Given this list of marker genes TDRD5, ANK3, JAG1, DIO2, CNTNAP4, ROGDI, CD68, PPOX (protoporphyrinogen oxidase), ASF1A, QRFP, NPM3, SMAD1, HIVEP1 (NCBI Gene Id 3096), ZNF593, GATA6, SLITRK1, TNFRSF12A (TNF receptor superfamily member 12A), PRKCH, CACNA1D, COMMD10, RHOD, ST3GAL5, DMD, ELMOD1, NHLH1, SP6, WDR73, ZMIZ1, ENSG00000291228 (novel transcript), FBXW7, MEPCE, TRAPPC14, LMNA, CYFIP2 (NCBI Gene Id 81032), EN1, MRPL17, JAKMIP2, ARMC6, RUNX1, OLFM4, DUSP9 (NCBI Gene Id 1852), TLE3, SYT12, TMTC2, LIN28A, BCAR3, DOCK7, STOML2, GDPD4, CLEC18C, SALL3, CASQ2, MYO1C, STMN2, TRPM8, CSHL1, SLC37A2, MYL1, BNC2, CRIM1, C12orf42, SMPX, CCDC71L, SARS2, SAMD12, INHBA (NCBI Gene Id 3624), FOXO4, VGLL4, PRKAG1 (NCBI Gene Id 5571), VCPKMT, ELAVL4, BZW2, LMO3, LINC00052, TMEM126B, CCDC122 (coiled-coil domain containing 122), FCHSD1, PRIMA1, PRDM8, GH1, CHRNA10, CREB5 (cAMP responsive element binding protein 5), ZCWPW1, CSH2, ZIC2, ZNF384, SIX1, SESN3, IL3, RLIM, PDZRN4, PRKAA1, TMEM119, SOX14, KCTD8, SPTB, ZNF579, TBR1, HOXA5, MACROH2A2, SEPHS1, IKZF2, RTN3, PIAS1, TRPS1, ADCYAP1, TMEM88, CSH1, ZIC5, TMIE, DPYD, POU2F1, RORB (NCBI Gene Id 6096), STK40, CLRN1, STK32C, LINC01565, UBE4B, MEIS2, GPR88, MKS1, TMEM74B, GBX2, TFAP2D, FGF12, ZNF516-DT, GORAB, SLC26A8, SPRYD3, ZBTB18, FHDC1, PRDX5, ATRNL1, BAIAP2L2, OTP, NIPBL, TMCC2, SKIL, MAPK9, DLST, STAC2, HOXB5, MSANTD2, LUC7L3, BMP4 (NCBI Gene Id 652), DICER1, RTN4, NRP1, OTUD7B, MRPS12, PDE2A, ZIC4, PKP4, EPO, MYBPC1, RIPK4 (receptor interacting serine/threonine kinase 4), ANKMY2, CALCR, UHRF1, VGF, MAP2, MYO15A, CPNE1, DPY19L3, DCX, HESX1, GRK6, WNT11, FOXD3, CYP46A1, PCSK5 (proprotein convertase subtilisin/kexin type 5), TRMT1L, MYH2, SOX4, ZIC1, FZD8, FGF9, RORA, THBS2, EIF4E, SLC25A26, PURA, GAP43 (growth associated protein 43), NAALADL2 (N-acetylated alpha-linked acidic dipeptidase like 2), PTPRD (NCBI Gene Id 5789), SYT16, EBF2, PRL, HDAC9, ZNF423, IL21, PIK3R3, HOXC6, HMCES, MAP3K13, PCF11, ESRRG, GPC3, ADAMTS5, SWT1, CDC42EP3, FLRT3, PRR34, BACE2, EN2, MYO18A, CDIN1, TIAL1, AQP3, CACNG2, DLGAP4 (DLG associated protein 4), ZNFX1, PHOX2B, DIAPH1, KRT20, NPHP4, TPH2, SKP1, TRMT112, TYRO3, IL5, APBB1, OTX2, SUGP2 (SURP and G-patch domain containing 2), HOXD10, PTHLH, PDLIM5, IARS1, KRT28, ZHX1, GTPBP1, DLX1, RRAGA, FMNL1, FOXP2, SLITRK4, CADM1, CNTNAP5, RBM39, FBXL19-AS1, here is a description of the gene set: Human Gene Set: POU1F1_Q6 studied in species Homo sapiens Genes having at least one occurrence of the motif ATGAATAAWT in the regions spanning 4 kb centered on their transcription starting sites. This matches the POU1F1 transcription factor binding site V$POU1F1_Q6 (v7.4 TRANSFAC).